The following is a description of a gene set: Human Gene Set: REACTOME_ACETYLCHOLINE_INHIBITS_CONTRACTION_OF_OUTER_HAIR_CELLS studied in species Homo sapiens Acetylcholine inhibits contraction of outer hair cells, and this is the list of marker genes: KCNN2, KCNMA1, KCNMB1, CHRNA10, CHRNA9